The following is a description of a gene set: Mouse Gene Set: GOBP_LIPOXIN_METABOLIC_PROCESS The chemical reactions and pathways involving a lipoxin. A lipoxin is a non-classic eicosanoid and signaling molecule that has four conjugated double bonds and is derived from arachidonic acid. studied in species Mus musculus, and this is the list of marker genes: Alox12, Alox15, Alox5, Cyp4f13, Ptgr1, Alox8